Given this list of marker genes Elf4, Inhbb, Sobp, Ldaf1, Hspb6, Kit, Pdik1l, Wee1, Ect2, Nhlh2, Arhgef12, Pak6, Epc2, Khdc4 (NCBI Gene Id 99643), Zmym3, Neo1, Adipor2, Bicd2, Zfc3h1, Kif16b, Zbtb7c, Esr2, Boc, Slitrk5, Atrn (attractin), Ubr5, Zkscan1, Slc14a2, Crim1, Mfsd6, Ero1b, Bcl11a, Brwd1, Ift56, Rad51d, Ccnj, Eif1b, Ddx3x, Zc3h6, Apcdd1, Zfp704, Zbtb21, Lypd6b, Pik3cb (NCBI Gene Id 74769), Klf6, Mrtfb, Lss, Ugt2b5, Il6, Papola, Gdap1, Adamts18, Mef2c, Adam9, Ddit4, Klhl18, Dyrk2, Btbd7, Neurod6, Mllt6, Aplf, Pcdh7, Kmt5b, Ythdf2, Prl4a1, Osbpl8, Twsg1, Mab21l1, 6430571L13Rik, Phf20l1 (PHD finger protein 20-like 1), Acsl4, Hnrnph3, Wdr48, Nalf1, Zdhhc17, Tfcp2l1, Itpr1, Atrx, Arhgef7, Plagl2, Hspa1b, Dctn4, Antxr2, Scn2a, Idnk, Irf2bp2, Tom1l2 (target of myb1-like 2 (chicken)), Pphln1, Cnn1, Csde1, Mnt, Hoxd8, here is a description of the gene set: Genes predicted to be targets of miRBase v22 microRNA mmu_miR_105 in miRDB v6.0 with MirTarget v4 prediction scores > 80 (high confidence targets). from publication Chen Y, Wang X (PMID 31504780) Mouse Gene Set: MIR_105 studied in species Mus musculus